Given this list of marker genes PKHD1L1 (NCBI Gene Id 93035), EXT1, SDSL, RGS1, HSPA6, MX1, HORMAD1, SLC31A1, PARP14, SMAD1, SLAMF8, PSMA4, IL15, EGR2, DMXL2, AQP9, DTX3L, NCF1B, TCN2, SLC6A12, NFIX, SHTN1, ICAM1, OASL, P2RX7, ACSL1, NFAM1, MNDA, AANAT, LILRA1, CTSB, IRF7, LPCAT2, GNB4, CLEC4G, TMEM51 (transmembrane protein 51), BST1, NECTIN2, EXOC3L1, MPZL2, TLR1, SRGN, TLR4 (toll like receptor 4), NGFR, S100A8, SERPINA1, EMILIN2, CREB5, DRAM1, HLX, LILRB5, ADM, OAS3, BEST1, SOD2, TREM1, SERPING1, CYP1B1, JAK2, NLRP3, WDR49, RAB39A, MARCKS, TDRD6, SBNO2, OPLAH, OAS1, SEPTIN4, RAB20, TRIB1, MSR1, TRPV4, GRINA (glutamate ionotropic receptor NMDA type subunit associated protein 1), SMTNL1, TNFAIP2, BMAL2, CTSS, SORT1 (sortilin 1), KCNJ15, IRAG1, GPBAR1, WDFY3-AS2, CDCP1, APOL2, GPR84, DUSP1, CLEC4E, MSRB1, CCDC149, HCK, SH3PXD2B, ANO5, EPSTI1, GPRC5C, IFITM3 (interferon induced transmembrane protein 3), PFKFB3, NMI, IFIT1, LTBR, MARCO, IRF1, DOCK4, TLR2, SLC31A2, FGL2, ZNF703, LILRA5, BATF2, IL31RA, DYSF, SAMD4A, FCGR2A, RNF217 (NCBI Gene Id 154214), CASP1, CYP27A1, FCAR, FCN1, CXCL10, APOL3, STAT1, FCGR2C, IL4I1, SQOR, ADAP2, TAP1, SIGLEC1, APOBEC3A, IGF2BP3, HCAR2, ANKRD34B, GLT1D1, TNFAIP6, ATF5, AIM2, PLA2G4A, CARD16, STAT2, LACTB, DHRS9, CCRL2, APOL4, GLUL, LRG1, NEXN, TMTC1, AIF1, P2RY12, FCGR1BP, RBM47, SOCS3, NCF1, HP, GCH1, CYP1B1-AS1, FGD4, PLBD1, GASK1B, STX11, PLSCR1, IDO1, TNFSF10, KREMEN1, IFI44L, SECTM1, COX17P1, CD14, IL27, LILRB1, SLC22A16, IL15RA, CCR1, BCL2A1, FPR2, DSE, TMEM150B, TMEM176A, MYOF, MIR22HG, SRC, PLXNC1, CD274, BACH1, ZMYND15, CASP7, CIMAP1B, C2, UBE2L6, H2BC18, CXCR2P1, MAFB, FAM151B, ACP3, BCL6, CDHR5, CMPK2, FAM20C, CDC42EP2, GNG10 (G protein subunit gamma 10), LHFPL2, CALHM6, IGSF6, ISG15, CD36, SCIMP, GBP4, SLC8A1, PSME2P2, TMEM106A, ZEB2-AS1, C1DP1, SCARB2, FBXO6, CES1, MORN2, ADPRH, FAM110B, SMCO4, SEMA6B, CLEC6A, PLA2G7, VCAN, PSME2, PLEKHG6, PSTPIP2, MEFV, DUSP6, LYN, DPYD, DUSP3, FAM241A, FAM20A, MCEMP1, KYNU, TRAFD1, MPEG1 (macrophage expressed 1), KLF4, LAP3, MT2A, LAMP3, LMO2, IFI35, OAS2, BLVRA, FAM72A, RAB31, IFI44, LILRA3, TMEM176B, SDC3, VRK2, SLC1A3, GCA, APOL6, LRRC4, BCL3, TNFSF13B, TFEC, SLC46A2, CCR2, IFI30, IFIT3, P2RY13, RSAD2, GBP5, LILRA6, ADAMTSL4, RUFY4, S100A9, WDFY3, DDX60, APOBEC3B, PRRG4, ZNF702P, CLEC4D, KCNJ2, DSC2, ALDH1A1, C1QA, S100A12, BATF3, DDO, CTSL, ETV7, IFIH1, CD38, LYZ, NAMPTP1, FOS, ASAP2, PKMYT1, SCO2, HSPA7, NPC2, SLC24A4, ASGR2, NHSL1, HBEGF, UBE2D1, FRMD3, FCGR1A, LIPN, CD300E (CD300e molecule), MS4A4A, PLEKHO1 (NCBI Gene Id 51177), LILRB2, SNX10, EGR3, FZD5, MEGF9, XAF1, C1QB, EPB41L3, TYMP, VDR, ITPRIPL2, STEAP4, IL1RN, SLC49A3, RHOQP3, NOD2, LINC00482, IFNGR2, SIGLEC16 (NCBI Gene Id 646039), IL1B, NCF1C, NLRC4, TGM2, SIGLEC11, IFI6, FPR1, GM2A, CARD17P, IFIT2, LILRB4, LMNB1, GBP3, PSMB9, PRLR, CASP5, C3AR1, NAMPT, ACVRL1, FAM157B (NCBI Gene Id 102724409), KCTD12, PLXDC2, ATF3, WARS1, MTHFD2, MUC1, HERC5, RTP4, CLEC5A, LRRK2, VAMP5, STK32B, CHST15, ADAM9, MCTP1, PARP9, APOL1, GBP1P1, SCARF1, CDKN1A, HLA-DQB1-AS1, RASGEF1B, FCER1G, AK4, ATP6V1B2, CRISPLD2 (NCBI Gene Id 83716), GBP2, LILRB3, SAMD9L, GBP1, XKR8, ANKRD22, CXCL16, FFAR2, here is a description of the gene set: Human Gene Set: HOWARD_PBMC_INACT_MONOV_INFLUENZA_A_INDONESIA_05_2005_H5N1_AGE_19_39YO_AS03_ADJUVANT_VS_BUFFER_1DY_UP from publication Howard LM, Goll JB, Jensen TL, Hoek KL, Prasad N, Gelber CE, Levy SE, Joyce S, Link AJ, Creech CB, Edwards KM (PMID 30566602) Genes up-regulated in peripheral blood mononuclear cell vaccinated with AS03 adjuvant vs phosphate-bufferred saline in adults (19-39) after exposure to inactivated monovalent influenza A/Indonesia/05/2005 H5N1 split-virus vaccine, time point 1D, administered i.m. BACKGROUND: Adjuvant System 03 (AS03) markedly enhances responses to influenza A/H5N1 vaccines, but the mechanisms of this enhancement are incompletely understood. METHODS: Using ribonucleic acid sequencing on peripheral blood mononuclear cells (PBMCs) from AS03-adjuvanted and unadjuvanted inactivated H5N1 vaccine recipients, we identified differentially expressed genes, enriched pathways, and genes that correlated with serologic responses. We compared bulk PBMC findings with our previously published assessments of flow-sorted immune cell types. RESULTS: AS03-adjuvanted vaccine induced the strongest differential signals on day 1 postvaccination, activating multiple innate immune pathways including interferon and JAK-STAT signaling, Fcgamma receptor (FcgammaR)-mediated phagocytosis, and antigen processing and presentation. Changes in signal transduction and immunoglobulin genes predicted peak hemagglutinin inhibition (HAI) titers. Compared with individual immune cell types, activated PBMC genes and pathways were most similar to innate immune cells. However, several pathways were unique to PBMCs, and several pathways identified in individual cell types were absent in PBMCs. CONCLUSIONS: Transcriptomic analysis of PBMCs after AS03-adjuvanted H5N1 vaccination revealed early activation of innate immune signaling, including a 5- to 8-fold upregulation of Fc-gammaR1A/1B/1C genes. Several early gene responses were correlated with HAI titer, indicating links with the adaptive immune response. Although PBMCs and cell-specific results shared key innate immune signals, unique signals were identified by both approaches. species: Homo sapiens